Given this list of marker genes Chuk, Akt3, Tsc2, Akt2, Cdkn1b, Mdm2, Cdkn1a, Akt1, Casp9, Mkrn1, Akt1s1, here is a description of the gene set: species: Mus musculus AKT phosphorylates targets in the cytosol Mouse Gene Set: REACTOME_AKT_PHOSPHORYLATES_TARGETS_IN_THE_CYTOSOL